The following is a description of a gene set: Mouse Gene Set: GOBP_COPPER_ION_TRANSMEMBRANE_TRANSPORT studied in species Mus musculus The directed movement of copper cation across a membrane., and this is the list of marker genes: Slc46a3, Slc31a1, Mmgt2, Atp7a, Slc11a2, Slc31a2, Atp7b, Steap2, Atox1, Slc39a11